Given this list of marker genes Tsku, Pax5, Uchl5, Nfix, Aqp1, Myh10, Dnah5, Dbi, Numb, Rpgrip1l, Atp1b2, Numbl, Kdm2b, Dpcd, here is a description of the gene set: The process whose specific outcome is the progression of the lateral ventricles over time, from the formation to the mature structure. The two lateral ventricles are a cavity in each of the cerebral hemispheres derived from the cavity of the embryonic neural tube. They are separated from each other by the septum pellucidum, and each communicates with the third ventricle by the foramen of Monro, through which also the choroid plexuses of the lateral ventricles become continuous with that of the third ventricle. Mouse Gene Set: GOBP_LATERAL_VENTRICLE_DEVELOPMENT studied in species Mus musculus